Given this list of marker genes Dlg1, Tfpi (NCBI Gene Id 99406), Ica1, Runx1, Acvr2a, Nr3c1, Mta1, Smad3, Fbln5 (fibulin 5), Scn8a, Igfbp5, Magi2, Cacna1a, Scaf8, Ldlr, Mrps31, Ythdc1, Nek7, Inpp4b (NCBI Gene Id 234515), Bhlhe40, Cdon, Igf1r, Plpp3 (phospholipid phosphatase 3), Pex14, Pias3, Anxa2, Tjp1, Mmp16, Efemp1, Rbpms, Lamc1, Fzd2, Sipa1l1, Atrn, Cdk13, Gcnt1, Bckdhb, Pik3r3, Myc, Nrp1 (NCBI Gene Id 270112), Map1b, Dyrk1a, Notch2, Rasa2, Map2k5 (mitogen-activated protein kinase kinase 5), Synj2, Celf2, Gja1, Cited2, Nfib, Adora2b, Cav1, Tgfbr3, Arhgef9, Pik3cd, Id1, Mapk14, Atp2b1, Rnd3, Grk5, Mgll, Dmac2l (distal membrane arm assembly component 2 like), Mgmt, Ptpn21, Nfkb1, Cdkn1b (cyclin dependent kinase inhibitor 1B), Tent4a, Bdnf, Aggf1, Snai2, Col5a2, Irs1, Mios, Anxa4, Amph, Dlc1, Serpine1, Apbb2, Schip1, F3, Dusp1, Insig1, Kit, Atrx, Ddah1, Sri, Bmpr1a, Vav2, Atxn1, Rxra, Cdc42bpa, Mt1 (metallothionein 1), Ccn1, Col1a2, Col3a1, Add3, Ltbp1, Tgfbr2, Dbp, Ptprm, Nr1d2, Nipbl, Vldlr, Pdgfrb, Sdc2, Pmp22, Phf3, Met, Kalrn, Atp2c1, Rgs4, Lpar1, Cap2, Erbb2, Fyn, Smad7, Pten, Akt3, Prdm2, Zmiz1, Prkce, Col11a1, Togaram1, Kcnma1, Col1a1 (NCBI Gene Id 217123), Adgrl2 (NCBI Gene Id 99633), Spop, Atp2b4, Abcc1, Itgb3, Pparg, Wdr37, Plcb4, Prkar2b, Sfmbt1 (NCBI Gene Id 78161), Fhl2, Dab2, Syne1, Prkca (NCBI Gene Id 18750), Slc22a18, Slc7a1, Pdlim5, Ptgfr, Has2, here is a description of the gene set: Mouse genes annotated to HALLMARK_UV_RESPONSE_DN based on orthology mappings provided by the Alliance Genome Consortium Mouse Gene Set: HALLMARK_UV_RESPONSE_DN from publication Howe DG, Blake JA, Bradford YM, Bult CJ, Calvi BR, Engel SR, Kadin JA, Kaufman TC, Kishore R, Laulederkind SJF, Lewis SE, Moxon SAT, Richardson JE, Smith C (PMID 30224793) studied in species Mus musculus